The following is a description of a gene set: species: Homo sapiens Human Gene Set: HP_RENAL_CORTICOMEDULLARY_CYSTS Renal corticomedullary cysts The presence of multiple cysts at the border between the renal cortex and medulla., and this is the list of marker genes: XPNPEP3, DCDC2, MUC1, CRB2 (crumbs cell polarity complex component 2), NPHP3, NPHP1, TMEM67, NPHP4, UMOD